Given this list of marker genes Itgb1, Svep1, Emilin1, Itga9, Madcam1 (mucosal vascular addressin cell adhesion molecule 1), here is a description of the gene set: Any integrin binding that occurs as part of the process of cell-matrix adhesion. Mouse Gene Set: GOMF_INTEGRIN_BINDING_INVOLVED_IN_CELL_MATRIX_ADHESION species: Mus musculus